Given this list of marker genes Myh7b, Rcc2, Pde7a, Gramd2a, Kmt2c, Tsc22d3, Snord49a, Rapsn, Spmap1, Usp53, Washc1, Gm24044, Amdhd2, Kctd5, Ubl3, Il4i1, Atp2a1, Tsg101, Cpt1c, Tnfrsf23, Ska2, Zfp607b, Lsg1, Ppdpf, Snord45c, H2ac5-ps, Prdx5, Acap3, Erfe, Mical1, Xpo6, Kctd10, Topbp1, Nf1 (neurofibromin 1), Ncl, Pnrc2, Zswim8, Med24 (NCBI Gene Id 97779), Dot1l, Tnfrsf25, Ddx5, Mlst8, Ankrd60, Cep295, Gas2l1, Mapk4, Gatb (glutamyl-tRNA amidotransferase subunit B), Hyal3, 5530601H04Rik, Ppp4r4, Fmc1, Ehd1, Snapc2, Ctnnal1, Gm12516, Eif4g2, Rita1, Tob2, Gm25789, Srsf7, Tmem30a, Cdkl2, Mnt, Lpp, Foxj3, Irf5 (interferon regulatory factor 5), Stk11, Gm9958, Gm8731, Ppp2r3d, Spred1, Akt2, Ephb2, Wdfy1, Cdca7l, Pttg1ip, Atp6v0c, Rusc2 (NCBI Gene Id 230094), Paip2, Klf6, B3galt4, Ap1g1, Aldh4a1, Capzb, Sec61a2, Adrm1, BC050972, F11r, Ecpas, Cox18, Tsc1, Arl6ip6, Gm24888, Ankmy2, Casz1, Gm15283, Ccdc138, Ppp3ca, Phrf1, H2bc11, Ptcd2, Vkorc1, Gm13567, Klc2, Zbtb37, Pik3r3, Pcgf2, Epo, Gm22310, Mir133a-1, Mutyh, Tpm3, Gm4473, Fip1l1, Atpsckmt, AI480526, Mrpl48, Mtf2, Dnm1, Nuak1, Mrps18a, Dusp3, Gm26224, BC065397, Rnf123, Malat1, Kifbp, Cacnb1, Wasf1, Gpr153, Thoc6, Rpl3-ps1, Dnajc13, Cdca8, Ist1, Spag9, Ap2m1, Npm1, Acbd3, Rpl3, Eed, Spire1, Ankrd13a, Limk2, Slc7a1, Nemp1, Gm11936, Sphk1, 2310043L19Rik, Psme4, Mtfr2, Nufip2, Gm23127, Cd68, Sec31a, Stimate, Poldip3, P3h1, Usp36 (NCBI Gene Id 72344), Anxa2, Trip12, Cenpu, Jpt2, Cspp1, Mirlet7i, Gfpt1, Rcc1, Pram1, Lpcat3, Agbl3, Zbtb46, Slc1a4, Srebf1, Nfic, Psip1, Aftph, Enah, 2900089D17Rik, Pusl1, Adpgk, Klhl40, Ipo13, Mrpl44, Mir7017, Mir7670, Pitpnc1, Tep1, Gm22847, Zfp882, Gpx1, Appl2, Tstd1, Psd3, Nexn, Arih1, Fitm2, 2300009A05Rik, Chd2, Gm26708, Usp33, Ndufb10, Rnasek, Rmc1, Elp1, Get3, Otud7b, Meis1, Tmem230, Tubb2a, Phip, Zcchc14, Nphp4, Uchl3, Osgep, Ablim1, Txndc12, Pbxip1, Hectd2os, Phlda1, Mia2, Mib2, Cacna1s, St6galnac2, Uqcrh, Pold1, Polg2, Zfp672, Clk1, Aloxe3, Stmn1, Thbs1, Rundc3a, Calu, Arpc4, Zbtb22, Rnf225, Hspa8, Lsm14a, Lypd6 (NCBI Gene Id 320343), 4930562A09Rik, Fn1, 4933440N22Rik, Slc25a11, Ddx25, Atg16l1, Sorbs2, Gm40190, Ccnb2, Tardbp, BC051019, Klf7, Prkci, B3gnt4, Bcl6, Tom1, Mir6972, Mir3075, Lgals1-ps2, Gm1720, Gm15393, Zfp768, Tmem260, Lamtor3, Ddx59, Ppp1r15a, Rab34 (RAB34, member RAS oncogene family), Ywhab, Rps6kb1, Samd1, Abcc5, Dgkz, Mettl6, Kank3, Plcb3, Nkapd1, Rbm20, Mapt, Gas5, Atg16l2, Prpf39, Kntc1, Ccnt1, Kif2a, Gm22748, Nsun4, Unc13d, Plekha8, Ybey, Mir23b, Phf3, Tor3a, Sf3b1, Fnbp1, Eno1, Pagr1a, Trmt2a, Cdiptos, Mapk6, Adamtsl4, Epn1, Rpl34, Mir687, Bzw2, Cacnb3 (NCBI Gene Id 12297), Ino80e, Map4, 1700008B11Rik, Atp5mg, Des, Mthfr, Snora73b, Trak2, Mir106b, Gm10433, Afmid, Fkbp3, Prc1, 4930577N17Rik, Slc16a8, Trap1, Eif1, Pmpcb, 4933431K14Rik, Rpl9, Donson, Gm24494, U2af2 (NCBI Gene Id 22185), Gtpbp2, Tmem126a, Mcm3ap, Ptbp3, Pdf, Cnih2, Scrib, Cmtr1, Edc4, Scmh1, Celf1, Chrd, Vamp8, Nckap5l, Calm1 (calmodulin 1), Mcm7, Rab40c, Polr1g, Zfp382 (NCBI Gene Id 73854), Cpsf1, Mir17hg, Luzp1, Gm5544, Krtcap3, Leap2, Otud7a, Gtf2a2, Adam19, Gm28913, Rrp9, Naa20, Xpo4, Col1a2, Clcc1, Gm17147, 1110038B12Rik, Vps72, Kdm4a, Wnk1, Tbx15, Cwc27, Mroh1, Bcar3, Tmed7, Psen1, Hmox1, Chd3 (NCBI Gene Id 93682), Snrk, Fndc3a, Cby1, Frat2, Agbl5, Haspin, Cct5, 4933406P04Rik (NCBI Gene Id 74420), Snhg6, Taok2, Usp48, Spen, Tapt1, Zfp236 (zinc finger protein 236), Dpy19l4, Asmt, Efcab2, Them6 (thioesterase superfamily member 6), Mnd1, Caskin2, Dcaf8, Wbp4, Nol8, Cdk16, Prss23, Rpusd3, Cnn3, Rnf6, Dap3, Arfgef1, Syncrip, Ndufaf3, Slc38a6, Steep1, Adat1 (NCBI Gene Id 30947), Cd164l2, Camk2d, Srsf1, Trmt1, Cfap298 (NCBI Gene Id 68001), Zfp948, Atf5, Arhgef40, Zfp229, Calm3, Gm23455, Sgsm3, Gm22357, Rnpep, Coq8b, Ccnd3-ps, Scand1, Pld3, Zfand2a, Ccni, Cdh13, Ap3s1, Psma3, Tada2a, Eml1, Hmgb1, 9230114K14Rik, Snhg5, Crybb3, Taf15, Ccdc97, Pim2, Trabd, Srsf3, Rxylt1, Scfd1, Tcp11l2, Cenpn, Atp6v0e, Nmral1, Gm22208, Mllt10, H3c6, Ube2d3, Saal1, Speg, Tmem62, Sacm1l, Spink10, Cops4, Rex1bd, Gm12915, Mdn1, Ptbp1, Vim, Evi2a, Gps2, Cdh24, Vezf1, Usp24, Rrm2b, Gm15559, Septin11, Pprc1, Rbm4b, Matr3, Piezo1, Col20a1, Aff4, Ccser2, H2bc6, Gm4221, Ergic1, Akap8l, Rtel1, Fbxo33, Map7d1, Dnaja2, a, Lyrm9, D030056L22Rik, Nap1l4, Mrps27, Nacad, Gm28809, 1700023H06Rik, Cltc, Nr2c2ap, Dnajc19, Xrcc3, Snord65, Agpat2, Mir7030, Capn10, Srxn1, Gm17800, Ppid, Slbp, Cdk5rap1, Pygm, Mir8094, Mat2a, Leng8, Ppp1r8, Cdc40, Nfyb, Paf1, Mid1, Mef2d, Gm22489, Qrfp, Ccnl1, 2310022A10Rik, Shb, Mprip, Pop5, Mcm4, Oga, Phgdh, Synpo2, Dnajb4, Chka, Gm26854, Casc3, Swt1, Atrip, Gm11175, Rnf167, Uap1, Maco1, Ppm1l, Hsd11b2, Anapc5, Selenos, Thsd1 (NCBI Gene Id 80649), Cul9, Mir215 (microRNA 215), Gm4285, Mir7079, Gm10373, Pbrm1, Tet2, Ccdc141 (coiled-coil domain containing 141), Diablo (diablo, IAP-binding mitochondrial protein), Dync2h1, Arhgef2, Ttc17, Rps27a, Gm4462, Kcnab2, Slc8b1, Dnm2, Gm25769, Gm22711, Prmt6, Tor1a, Flcn, Pum2, Tmem63a (NCBI Gene Id 208795), Rfc4 (NCBI Gene Id 224052), Zwilch, Stim2, Stam, Cct8, Polg, Rps18, Cimip2a, Gabpa, Cnot6, Maf, Bcl9l, Ss18, Coro7, H3c2, Kansl2, Espn, Skic8, Dgkd, Foxk2, 4930580E04Rik, Lat2 (linker for activation of T cells family, member 2), Rad52, Gm7399, Tnks2, Map4k4, Col3a1, Slc2a4rg-ps (NCBI Gene Id 329584), Prpf40a, Mir6935, Obscn, Cep104, Nfe2l1, Ercc1, Tapbp, Ap1b1, Snrnp27 (small nuclear ribonucleoprotein 27 (U4/U6.U5)), Nol11, Get4, Actg1, Ttll7, Ulk4, C330013E15Rik, Rab11bos1, Car3, Pfdn4, 4921536K21Rik, Epb41l5, Hivep2, Eif4a1, Snord2, Gm6963, Spmip10, Med16, Gm27003, Gm25636, Pkp4, E2f3, Chd8, Josd2, C130036L24Rik, Cldn15, Kdm3a, Gm10785, Ddx23, Raly, Phtf1, Tfip11, Isy1, Stau1, Iqch, Ftl1, Cpsf2, Zfas1, Antkmt, H2bc13, Mir27b, Impdh2, Pam16, Msmo1, 1700001L05Rik, Desi2, Actr3, Fgfr3, Ptms, Mybbp1a, Ywhah, Mir93, Apex1, H4c1 (NCBI Gene Id 326619), Afdn, Filip1, Susd2, Ube2g2, Ptcd3, 4930578M01Rik, Fryl (NCBI Gene Id 75575), Sharpin, Mettl23, Rpl7a, Usp35, Gm26447, Nme2, Brd2, Cul4a, Napepld, Yars1, Mynn, Extl1, Ankfy1, Ube2j1, Zfr, Cul2 (cullin 2), Gm11398, F830045P16Rik, Tecr, BC046401, Flna, Etfrf1, Lrrc8b, Rbm39, Ncam1, Morf4l2, Srp72, Smg8, Actn4, Tpt1, Gm24958, Tssc4, Ktn1, Stxbp5, Midn (NCBI Gene Id 70193), Sanbr, Tspyl3, Rrp7a, Tex14, Cfap77, 2510016D11Rik, Rad23a, Trmt5, Smad3, Pnkp, Micu1, Nol7, Anln, Cfap69, Dusp5, Brat1, Ubxn6, Smim24, Cd164, Psmd12, Fam193a, Bbc3, Rabggtb, Mfsd10, Slc9a9, Coq3, Erp29, Ighmbp2, H3c10, 4930558J22Rik, Gmeb2, Dnai7, Atp13a3, Fbxw9, Hba-ps4, Gm24299, Rps11, Tmcc1, Ajuba, Cyren, 5430416N02Rik, Mrpl49, Wipf2, Usp34, Mpst, Asb3, 2610507I01Rik, H2bc7, Fam20b, Clhc1, Eogt, Vma21, Tusc2 (tumor suppressor 2, mitochondrial calcium regulator), Rplp0, Klc1, Tnnt1, Nop58, Mrps26, S100a16, Avil, Ywhaz, Aebp2, Preb, Rps18-ps2, Abhd16a, Ryr1, Scly, Dpp9, Sun1, Safb, Gm22744 (predicted gene, 22744), Klc3, St6galnac6, Pygo2, Ccdc85c, Tsen54, Gm14286, Dffb, Gmpr, Sugp2, Ahdc1, Pxn, Nab2, Rexo1, Usp20, Eif3b, Acsl3, Aagab, Esyt2, Vta1, BC005537, Ankrd39, Hdac2, Hdac1, Gprc5c, Gipc1, Nop56, Uros, Msh4, Mettl21c, Naa15, Rnf44, Gm26138, 3110045C21Rik, Pomt1, Tagln2, Rnf24, Bbs10, Rae1, Bud13, Lrrc75aos2, Etv4, Cep44, Snhg3, Zzz3, Mir6963 (NCBI Gene Id 102466775), Pip4k2b, Sqstm1, Septin1, Cldn22, Igsf3, Fam53c, Yars2, Nadk, Nxf1, Kpnb1 (NCBI Gene Id 16211), Mir760, AW112010, Snx14, Gm23246, Fbxo36, Dph7, Abca7, 1110002L01Rik, Mfsd2b, Ighv10-2, Atp2a2, Vps33a, Snord104, Ino80b, Pih1d2, Rps15a, 4833445I07Rik, Gm16251, Ogt, Gm42922, Rbm26, Sipa1, Purb, Uba1, Mdm2, Snord12, Fam174c, Gm12764, Dstyk, Eef1d, Nit1, Ikzf5, Snord52, H3c15, Dyrk2, Akirin1, Abhd10, Myom3, Stoml2, Gnpat, Nectin2 (NCBI Gene Id 19294), Mir25, Frmd4a, Ccdc57, Mtres1, Kmt5b, Chmp3, Arid5a, 4930404A12Rik, Tuba4a, Utp3, Gm16062, Tcf3, Top1, Lrp6, Pxk, Gpx4, Rbm22, Dcaf11, Serpinb6a (NCBI Gene Id 74999), Gm9754 (predicted gene 9754), Prrc2b, Ewsr1, 1700047K16Rik, Phka2, 1600020E01Rik (NCBI Gene Id 72012), Usp19, Gm12703, Rasl10a, Stab1, Crk, Gm21992, Mir546, Gm13267, Hrob, Htra4, Gm15706, Rps19, Dgat2, Myadm, Inava, Tmed2, Sft2d3, Cdan1, Glmp, Dlg1, Galnt10, Pdlim2, Ccdc88a, Gpr151, Txn1, Cstf3, Exosc3, Dusp16, Dnajc5, Ttc41, Ctsk, Ccdc142os, Madd, Zfp609, Gsto2, Nr1d1, Snora81, Neurl4, Ly6g5b, Mtss2, Synrg, Ap3m1, Zcchc24, Tatdn2, Evi2, Ing1, Cript, Usp25, Kctd2, 4930429F24Rik, Relt, Pdcd6, B3gnt5, Gm16759 (NCBI Gene Id 102639582), Oxr1, Lrrc27, Pfdn2, Gm9917, Cers2, Bzw1, Plk4, Gm13524, Lmln, Cep170, Arhgap23, Arhgap28, Gm17501, Pkia, Brd7, Acadsb, Mir31, Gm25630 (predicted gene, 25630), Npnt, Coq8a, Eci1, Slc31a1, Fscn1, Pknox1 (NCBI Gene Id 28068), 2410004B18Rik, Pcid2, Snora52, H2ac6, BB557941, Wwp1, Fam161a, Mir206, Sri, Akr1b7, Pdia2, Trmt112, Fbxl14, Cnot6l, Eif4a3, Pten, Ctnnd1, Epb41l4aos, Mir7077, Sash1, Etl4, Mfsd14a, Atg7, Urgcp, Ago4, Apol8, Nup214, Adnp, Ttn, A430057M04Rik, Myod1, Ppp1r13l, Mrnip, Snora33, Hnrnpk, Gm26254, Tmem182, Dapk3, Fosl2, Sema3d, Slc6a18, Pld6, Fam47e, D330041H03Rik, Oit3, Bmi1 (NCBI Gene Id 12151), Cap1 (NCBI Gene Id 12331), Rps17, Mir378b, Dnmt1, Prkdc, Kmt2a, Wtap, Ift81, Hap1, Hoxa11os (homeobox A11, opposite strand), Per2, Tmx3, Nmbr, Cd81, Hnrnpf, Gm15587, Rrbp1, Hspa5, Sirt1, Gm14010, Abl1 (NCBI Gene Id 98922), Synj2, Atosb (atos homolog B), Zfp335, Gm24201, Ndufb2 (NADH:ubiquinone oxidoreductase subunit B2), Synpo2l, Gm12267, Rplp2, Otud4, Smpd2, Mir6922, Dop1a, Snord17 (small nucleolar RNA, C/D box 17), Slc35c2 (NCBI Gene Id 97018), Tada3, Hnrnpm, Rpn2, Gm16066, Smad7, Atp6v1f, Crygs, Gm4734, Capn15, Phlda3, Crabp2, Sinhcaf, Eftud2, Gm11335, Kmt2d, Stac2, Dusp10, Ccng2 (NCBI Gene Id 12452), Gm19610, Mrpl21, Ube2d-ps, Slc17a9, Eif4a2, Gm13830, Obsl1, Col13a1, Lincmd1, Colgalt1, Cyth1, Jup, Cops5, Alkbh1, Plcd3, H3c8, Csnk1d, Timm44, Srsf4, 4931440P22Rik (RIKEN cDNA 4931440P22 gene), Tns1, Wdr5b, Dnah10, Tigd5, Tradd, Pex11b, Gm23639, Gm6044, Phldb2, Rnu11, Prmt3, Gm24357, Pcmtd2 (NCBI Gene Id 98894), Arf4, Ttc4, E230016M11Rik, Cisd2, Tacc1, Slc15a4, H2bc8, Cenpp, Pgk1, Gabpb1, Bdp1, Slirp, Mapkbp1, Gm10322, Cldn7, Rft1, Gm25549, Hes6, Klf4, Helz, Myo18a, Vps52, Hsd17b7, Becn1, Fchsd2, Hadha, Hmgb3, Toe1, Tmc4, Cbx5, Ppt2, Odf2, Dut, Adam32, Tnfaip2, Eif4g1, Gm15459, 2510002D24Rik, Gm12846, Fbxo11, Gm25132, Nprl3, Sumf2, Gm23201, Gm24453, Zc3h4, Hmgn1, Dnajb14, Lmna, Myh9, Ttc39d, Ash1l, Gm24134 (NCBI Gene Id 115489586), Lnpk, Dynll1 (NCBI Gene Id 56455), Golga1, Morrbid, Pim1, Smc3, Frat1, Fam227a, Erlec1, Rnf151, Zfp282, Tgif1 (NCBI Gene Id 21815), Cnbd2, Pcbd2, Neat1, Neb, Junos, Pcf11, Tnfsf13, Dync2i2, Tle3, Thap6, Cdk13, Ereg, Prr29, Atrnl1, Psat1, Mrpl18, Idh3g, A130050O07Rik, H2ax, Rbm4, Anxa3, Aida (NCBI Gene Id 72487), Rpl30-ps6, Ube2a, Dcaf10, Pdlim5, Elmo3, Ddx54, Lrfn4, Atp5pd, Cfb, Prl2c3, Hells, Kmt2e, Zfp422-ps, Ldlrad2, 0610009L18Rik, Mir22hg, Ociad1, Lrp1, Mblac1, Parp3, Cdt1, Zfp513, Selenow, Map2k2, Gm17494 (predicted gene, 17494), Gm7785, Paxip1, Zc3h10, Prkag1, Ell, Snord22 (NCBI Gene Id 100127111), Hyal2, Atg101, Cnnm3, Gm22879, Atg12, Polr1a, Arrdc3, Nop2, Zfp82, Spaca6, Osbpl9, Bccip, Hnrnpl, Rps12-ps26, Apbb2, Ndufs8, Prrt2, Aldoa, Snora73a, Snord73b, Ncor2, Hsd17b8, Gm26704, 4931406C07Rik, Pan3, Sirt7, 4930539J05Rik, Tspan9, Asah1, Ggnbp2, Zfp617, n-R5s65, Cdipt, Gm24608, Gm15816, Lzts2, Cers1, Ciz1, Pmvk (NCBI Gene Id 99841), Ell3, Proca1, Trim59, Srek1ip1, Fam20c (FAM20C, golgi associated secretory pathway kinase), Gm15545, Ftsj3, Ercc3, Tacc2, Gm13015, Gm4189, Mir133b, Nfya, Lrrc41, Mpdu1, Ap5z1, Dgat1, Coq5, Tigd3, Gm10250, Vcpkmt, Slc25a3, Rnaseh2c, Gm4924, Gm20652, Gramd1a, Znhit6, Zfp644, Tmem120b, Fus, Gm5973, H2ac11, Adgrg6, Nat10, Pus3, Gm27252, Fam131a, Ctnna3, Fgf18, Aars1, Lias, Chchd2, Herpud1, Gm14022, Kpna2, Gpc1, Fbxl8, Spsb3, 1700054O19Rik, Cmc2, Diaph1, Psmd11, Musk, Gm22362, Gm22663, Tbrg4, Arfgap2, Abraxas1, Tektip1, Zfp219, Chek1, Tor1aip1, Gm13687, Nras, Pcbp1, Hsp90aa1, 4921514A10Rik, Ubr4, Jpx, Klf3, Fam50a, 5031425E22Rik, Dysf, Vegfa, Lockd, Zfp451, Ube3b, Znfx1, Myl12a, Sod2, Plcg1, Myhas, Mterf3, Gbf1, Slc35e2, Lama5, Gcn1, Gm22680, Gnb2, Gm12279, Wasl, H2bc18, Cracr2b, Por, Cep95, Kansl3, Mrpl39, Rps6ka2, 1110046J04Rik, Rhbdd3, Gm24455, Runx1, Frg2f1, Mir194-1, Hsbp1, Snora24, Nbr1, Kif5b, Fermt2, Gnas, Tlcd2, Rnf181, H4c9, Gm15535, Ube2b, Gm16364, Rhof (ras homolog family member F (in filopodia)), 4930473A02Rik, Amotl2, Chn1 (NCBI Gene Id 98942), Bclaf1, Mfsd4a (major facilitator superfamily domain containing 4A), Cimip2b, Cflar (NCBI Gene Id 98571), Iffo1, Gm24452, Lrpprc, Cyb5r3 (NCBI Gene Id 97979), Plec (plectin), Ccl25, Ankrd17, Fancc, Dazap1, H3c4, Plpp5, Nisch, Bcl2l12, Cln8 (NCBI Gene Id 26889), Sh3glb1, Celf2, Rps5, Cp, Kalrn, Papola, Cops7b (NCBI Gene Id 27992), Ap2b1, Greb1l, 1700056E22Rik, Tst, 4833420G17Rik, Lims1, Tpm1, Dhx30, Vars1, Btf3l4, Ppp6r3, Mir6936, Tmem116, Pafah2, Uggt2, 1700022N22Rik, H2ac15, Kcnj13, Kif1b (kinesin family member 1B), here is a description of the gene set: Mouse Gene Set: PEX2_TARGET_GENES studied in species Mus musculus Genes containing one or more binding sites for (Pex2) in their promoter regions (TSS -1000,+100 bp) as identified by GTRD version 20.06 ChIP-seq harmonization. from publication Yevshin I, Sharipov R, Kolmykov S, Kondrakhin Y, Kolpakov F (PMID 30445619)